Given this list of marker genes Fgf9, Fgf15, Pik3ca, Ptpn11, Pik3r1, Fgfr4, Fgf1, Fgf20, Grb2, Fgf4 (NCBI Gene Id 14175), Frs2, Fgf8, Fgf18, Fgf16, Klb, Fgf6, Fgf23, Fgf2, Gab1, Fgf17, here is a description of the gene set: species: Mus musculus Mouse Gene Set: REACTOME_PI_3K_CASCADE_FGFR4 PI-3K cascade:FGFR4